The following is a description of a gene set: studied in species Homo sapiens The multiplication or reproduction of fibroblast cells, resulting in the expansion of the fibroblast population. Human Gene Set: GOBP_FIBROBLAST_PROLIFERATION, and this is the list of marker genes: HTN3, FBXO4, ECD, E2F8, PEX2, FAM114A1, S100A6, DHX9, SKI, EMD, GSTP1, ESR1, TGFB1, VEGFD, CDKN1A, JUN, CDC6, FTH1, CDK1, CD300A, CDK4, FBLN1, LTA, AQP1, SOD2, WNT1, ABL1, LIF, MIR17, NGFR, HRAS, CCNA2, CTC1, BAX, MYC, IFI30, EREG, PDGFC, FGF10, GNG2, CD248, GAS6, PAWR, PLA2G1B, NLRC3, SIRT6, MIF, B4GALT7, CKS2, BTC, BMI1, PARP10, RRN3, CDC73, MYB, FOSL2, LIG4, KCNJ8, DAZAP1, NUPR1, CREB1, PDGFA, DPH1, INCA1, TP53INP1, SFRP1, CAV1, KDM8, TGIF1, PDGFRA, DAB2IP, MED25, CD74, KAT2A, PML, CCNB1, PRDX1, WNT7B, TP53, COL3A1, ZMIZ1, PDGFB, CDK6, C6orf89, PDGFD, ITGB3, ZMPSTE24, SPHK1, RNASEH2B (NCBI Gene Id 79621), KMT2A, C1QL4, WNT2, ING5, LZTS2, MORF4L1, DACH1, CTNNB1, WNT5A, IGF1, E2F1, MED31, AGT, HMGA2, MIR494, IL13, ABCC9, MORC3, DDR2, NF1, FN1, EGFR, TRIM32, BRK1, GPX1